The following is a description of a gene set: Genes up-regulated in NHEK cells (normal keratinocytes) by UV-B irradiation. To gain insight into the transformation of epidermal cells into squamous carcinoma cells (SCC), we compared the response to ultraviolet B radiation (UVB) of normal human epidermal keratinocytes (NHEK) versus their transformed counterpart, SCC, using biological and molecular profiling. DNA microarray analyses (Affymetrix), approximately genes) indicated that the major group of upregulated genes in keratinocytes fall into three categories: (i). antiapoptotic and cell survival factors, including chemokines of the CXC/CC subfamilies (e.g. IL-8, GRO-1, -2, -3, SCYA20), growth factors (e.g. HB-EGF, CTGF, INSL-4), and proinflammatory mediators (e.g. COX-2, S100A9), (ii). DNA repair-related genes (e.g. GADD45, ERCC, BTG-1, Histones), and (iii). ECM proteases (MMP-1, -10). The major downregulated genes are DeltaNp63 and PUMILIO, two potential markers for the maintenance of keratinocyte stem cells. NHEK were found to be more resistant than SCC to UVB-induced apoptosis and this resistance was mainly because of the protection from cell death by secreted survival factors, since it can be transferred from NHEK to SCC cultures by the conditioned medium. Whereas the response of keratinocytes to UVB involved regulation of key checkpoint genes (p53, MDM2, p21(Cip1), DeltaNp63), as well as antiapoptotic and DNA repair-related genes - no or little regulation of these genes was observed in SCC. The effect of UVB on NHEK and SCC resulted in upregulation of 251 and genes, respectively, and downregulation of genes in NHEK and genes in SCC. To further analyse these changes, we used a novel unsupervised coupled two-way clustering method that allowed the identification of groups of genes that clearly partitioned keratinocytes from SCC, including a group of genes whose constitutive expression levels were similar before UVB. This allowed the identification of discriminating genes not otherwise revealed by simple static comparison in the absence of UVB irradiation. The implication of the changes in gene profile in keratinocytes for epithelial cancer is discussed. species: Homo sapiens Human Gene Set: DAZARD_RESPONSE_TO_UV_NHEK_UP from publication Dazard JE, Gal H, Amariglio N, Rechavi G, Domany E, Givol D (PMID 12771951), and this is the list of marker genes: KRT34, NCBP2, PPP2R1A (protein phosphatase 2 scaffold subunit Aalpha), SEC61G, CCL20, MYF6, ECHS1, CHRNB4 (cholinergic receptor nicotinic beta 4 subunit), CRYBA4, STK17B, ACO2, CCDC85B, COL19A1, CDKN1C, DLX2, ZNF330, LAMA2, TRIM15, H2AC16, TXN, JUND, RAP1A, RPL30, EIF3G, H2BC7, CYP11B1, TCN1, IL1RL1, GCHFR, SURF1, HTR4, SPTBN1, UBE2M, NEFM, APRT, CRADD, IER2, NEU1, HSP90AB1, NUCB1, PPP1R15A, RPL34, CAPNS1, GEM, IGFBP6, TUBB2A, ARHGDIA (NCBI Gene Id 396), RALY, H1-10, INSL4, MT1G, MNAT1, ATP5ME, GAD2, SPINK1, HLA-F, CXCR3, GAST, STAT6, RPS17, ODC1, MMP10, RANBP1, ITPR1, PDLIM5, LINC03124, GFUS, ERCC1, PMS2P1, NDUFA1, SNRPE, SFI1, RPL38, PAX8, CXCL8, XBP1, MVP, PSMD8, KYNU, YKT6, TUBB3, COX17, TOM1 (NCBI Gene Id 10043), GADD45A, COX7C, SLURP1, IER3, HCRT, RPS27, CXCL1, HMGCS2, RPL31, API5, RCAN2, RPL37A, NDUFC1, DUSP1, HRAS, H2AC8, NR4A2, CLTB, HSPA2 (heat shock protein family A (Hsp70) member 2), CCNA1, GUK1, OAS2 (2'-5'-oligoadenylate synthetase 2), H2AC18, CXCL3, PHLDA1, CCNT2, MYL6, TAGLN, RPS23, CHRNB1, TAGLN3, APC2, KLK13, ZNF623, RRP7A, CCN1, DYNLL1, TGFB1, GATC, H2AC20, UBE2S, RNU1-11P, ADM, PPIF, TUBB4A, TNFAIP3, ANXA2P3, TSC22D1, RACK1, PRAMEF1, TUBB4B, H2BC6, CITED2, MAOB (monoamine oxidase B), NKX2-1, TFE3, H2AC13, TXNL4A, NOL7, NREP, PKM (pyruvate kinase M1/2), FOXC1, ZFP36, APOE, PRDM1, BCL2L11, BTG1, HEXIM1, PRSS3, COL11A1, UQCRB, TACSTD2, PTGS2, JUN, ANXA2, CEACAM1, LY6E (NCBI Gene Id 7999), H2AC7, TYMP, POP7, ATF3, TK1, TM4SF1, S100A9, SCG5 (NCBI Gene Id 6447), CCN2, RPL36A, CXCL2, ERCC2, TOB1, CTCF, KNG1, RPSA, CDH16, RPS2, CYBA, CYP2J2, TIMM44, ID2, PLXNA3, CST6, CCK, EIF1B, PPBP, SOX15, NR1D1, ERGIC3, H2AX, CSRP1, BAMBI, JUNB, RPL37, STXBP2, BRD2, CDK16, FOS, TRIB1, BBLN, PGK1, PHLDA2 (NCBI Gene Id 7262), QPCT, PFN1, CLDN4, GPAA1, GPI, SULT2B1, TGM3, PCK2, GADD45B, PIK3R3, BCL2, PMAIP1, HBEGF, SNHG3, GPS2, COX7A2, ATF4 (activating transcription factor 4), RPS21, SGK1, IL6